The following is a description of a gene set: Genes up-regulated in macrophages differentiated in the presence of IL4 and dexamethasone for 5 days versus those subsequently treated with TGFB1 for 24h. from publication Gratchev A, Kzhyshkowska J, Kannookadan S, Ochsenreiter M, Popova A, Yu X, Mamidi S, Stonehouse-Usselmann E, Muller-Molinet I, Gooi L, Goerdt S (PMID 18453574) Human Gene Set: GSE7568_CTRL_VS_24H_TGFB_TREATED_MACROPHAGES_WITH_IL4_AND_DEXAMETHASONE_UP species: Homo sapiens The goal of the study was to identify the effects of TGF-beta on primary human macrophages maturated under different conditions., and this is the list of marker genes: PFKM, CEP152, BLTP3B, MAP3K8, MECR, TLE6, FPGT, RECK, TEX9, HNRNPH1, RNF149, FBXO32, GPHN, BEND6, HLF, MOB1B, DDX10, ANKRD37, CLK1, DZIP1, LAX1, HECA, ELK4, ATP13A2, CLIC5, IL12RB1, TFAM, TAFAZZIN, ZYX, STX4, KIF2A, ASAP1, FLNB, TMCC3, IL15, TMEM17, ERICH2, PARL, CA2, RHBDF1, MS4A6A, STARD7, RNF169, SLC36A4, FCHSD1, IL18RAP, RNF114, HOOK2 (NCBI Gene Id 29911), HLCS, PDCD2, TUG1, TPD52, EFR3A, GLUD1, ITGB2, ANKRD42, NLRC3, ADAMTS10, NKAP, LRP5, PSIP1, SLC35G1, IGKC, ZNF81, STAT2, CERT1, DNAJC10, ABRAXAS1, GAB1, FURIN, CNTLN, KANSL3, KALRN, GIMAP6, STAR, NKX2-3, TECPR1, CD86, PDE7B, FOXO3, SPOPL, KAT6A, TBXAS1, ZFP36L2, RIPOR2, RETREG1, MAN1C1 (mannosidase alpha class 1C member 1), TIRAP, RFTN2, ATP8B2, MTSS1, TENT5A, SOS1, MIEF2, MAMDC2, MN1, VEGFC, RYBP, GPR65, RAI2, ZSCAN26, MB21D2, CD48, SMAGP, SMPDL3A, NAP1L3, SCML2, PLPP6, ZNF878, ZNF146, PNPLA8, WNT5B, DPH1, PSD3, GIMAP8, SLC24A3, ARGLU1, EIF1B, RNASE4, ESCO1, ITGA4, TMEM106B (NCBI Gene Id 54664), CD74 (CD74 molecule), UPF2, OOSP2, RDH5, WRNIP1, SLC26A6, HEMK1, HMGA2, ACP2 (NCBI Gene Id 96117), SNX29, ASB7, SLC30A4, ZNF770, ADCY9, ZNF281, SAV1, SBSN, CEP290, ATP8A1, HGFAC, ADRB2, DIP2C, ARHGAP15, ZNF512, CTNNA1, MEX3B, AP2A2, CUL4B, PTCD3, ARMC3, MFNG, CARD6 (caspase recruitment domain family member 6), CLSTN1, BIRC2, LRRC49, CNRIP1, RAB23, RHOB, RNF24, AMER2, EPS15, MAGEH1, CCNK, NDUFS2, DDX55, MIER3, PTBP2, FAM32A, ZC3H14, RAP2A, DDX5, N4BP1, PAK1, IKBKB, SPTY2D1, FZD6, CD53, ANG, HDAC2, RSRC2, TBC1D32 (TBC1 domain family member 32), SMIM3, CCDC90B, CDK19, DOP1B, NCAPG2, ECI1, PITX2, POLR3G, RAB32, FIRRE (firre intergenic repeating RNA element), PBLD, RICTOR, SLF2, PAFAH2 (NCBI Gene Id 5051), FBXO38, CD84, HOOK1